Given this list of marker genes PARK7, DHRS4L1, ADH4, AKR1C1, PCK1, GLO1, IDH1, ALDH8A1, AKR1A1, GRHPR, ABCA4, TALDO1, ALDH2, CYP11B1, ALPL, AGXT, ALDH7A1, WNT4, HYI, ALDH3A1, AKR7A2, RPIA, MGAT4A (alpha-1,3-mannosyl-glycoprotein 4-beta-N-acetylglucosaminyltransferase A), TKT, CACNA1H, REST, KDM3A, CYP11B2, BMP5, ESD, DKK3, SDR16C5, BMP2, GATD1, RPE65, EDNRB, AKR1C3, BCO2, ALDH1A2, IDH2, RPEL1, DHRS4L2, HOGA1 (NCBI Gene Id 112817), TPI1, PNPO, PDXK, RDH10, ALDH1A3, ALDH3B2, SHPK, CYP1B1, BMP6, PDXP, ALDH1A1, RDH11, ALDH3B1, DHRS4, CYP27C1, RPE, SCNN1B, CLCN2, TKFC (NCBI Gene Id 26007), ALDOB, RDH13, ALDH3A2, ADH5, RBP4, BCO1 (NCBI Gene Id 60483), SLC25A10, HAGH, DAB2, PNKD, GLYCTK, AGXT2, ALDH9A1, AKR7A3, here is a description of the gene set: The chemical reactions and pathways involving aldehydes, any organic compound with the formula R-CH=O, as carried out by individual cells. Human Gene Set: GOBP_ALDEHYDE_METABOLIC_PROCESS species: Homo sapiens